Given this list of marker genes SERBP1 (SERPINE1 mRNA binding protein 1), STARD4, RBM20, ABHD13, ZBTB8A, MOSMO, KIAA0408, PM20D2, RORA, TTC28, DCBLD2, CLP1, NAMPT, UBE2D1, NEK1, UNC5D, PIK3R1, RASD1, FMNL2, PANK1, ERBIN, KRTAP2-4, RSBN1, ABCC2, DMD, PAPOLG, FBXW2, SKIL, SMC1B, FOXN2, INO80D, LEPROTL1, MXD1, RPS6KA6, TMEM131, GPC6, FAT1, DNAJB1, FZD6, PLAGL2, HDX, CDK14, SORCS1, ERGIC2, CREBRF, NOTCH2, GOLM2, TRMT9B, TANK, ZNF830, SPATA31A1, MTRF1L, ADISSP, SASH1, GRIA2, GSE1, SCG2, ANKRA2, SPRED1, POU3F1, SPTSSA, EGLN1, HIPK2, ZFP30, TDRP, CCDC71L, PDCL3, TNRC6B, SUZ12 (NCBI Gene Id 23512), FKBP5, TBL1XR1, COPS2, IQGAP2, UHRF1, CDS2, GRIN3A, CTXN2, PRR14L, SLC2A13, TMEM64, B4GALT4, ZBTB22, TMEM170B, IGF2BP2, TAF9, DYRK2, ANO3, DAG1, COLGALT2, GIGYF1, MCU, CDK17, PDE1C, HDAC8, ZBTB34, RP2, SOHLH2, ATL3, HSPH1, MARK1, CIPC, HOXD13, ING3, WNT5A, KPNA4, PIK3CA, PAN3, DND1 (NCBI Gene Id 373863), TBCA, NOL7, CREBBP (CREB binding protein), SNX12, SETD7, RC3H1, OTUD7B, PDS5A, AZIN1, TSEN15, TAOK1, KIN, CABLES2, RBM46, EMP2, SETD3, LARP4, HNRNPC, LIN7C, TNFSF11, INPP4A, AKAP10, STAC, RUNDC3B, ICAM5, ZNF468, LRRC37B, NTF3, HDGFL2 (NCBI Gene Id 84717), WNK3, DCLK1, MCM9, POLD3, USP38, TLL1, SON, AKT1, RETSAT, ZC3H12C (zinc finger CCCH-type containing 12C), MARCKSL1, TMPO, KMT2C, HUWE1, USP49, CASC3, SPATA31A7, HOXD8, LOXL2, ZNF566, DOCK10, ADARB2, SPIN1, XPR1, SIDT2, TRHDE, RSPRY1, EREG (epiregulin), MITF, FHIP1A, PCDH20, MYBL1, MAML3, TTC14, ERO1B, ANKRD28, RSRC1, MAFB, DNAJA2, VAV2, MATR3, MID1, VSTM2A, SMIM10L1 (small integral membrane protein 10 like 1), DDX5, CA13, SMIM7, SLC10A4, MED1, TMPRSS15, STIM2, EIF4G2, NDUFA4, ZFAND5, SCAI, HELZ, YPEL5, TRIM28, IRX2, RASA2, PSD3, SOS2, KIRREL1, LLGL2, CACNA2D1, CCZ1B, DIS3L2, TAF7L, CPNE8, SOCS5, IL6, SEPTIN2, ATP6V0A2, MARCHF5, MAGOHB, PPM1B, BCL2L11, SYNCRIP, ZCCHC14, KIAA0232, PITPNB, LSM14A, ZBTB43, PELI1 (pellino E3 ubiquitin protein ligase 1), PRKAR2B, ERP44, CRLS1, ABI2, HMGCS1, DNAJB12, B3GALT2, AHSA2P, NUFIP2, ITPA, NAV2, ARL6IP6, PDE7A, QTRT2, VKORC1L1, BCOR, PPP1R2, NPAS3, VEZF1, EPC1, POLR1A, HIF3A, ERI1, ELOC, ZNF148, NCL, RGPD1, LOXL1, B3GNT5, PDCD7, ARAP2, FIGNL1, ZNF614 (zinc finger protein 614), PLGRKT, WWP1, G2E3, SBK1, MAPK6, KDM7A, TMEM128, RB1CC1 (RB1 inducible coiled-coil 1), YTHDF3, GPD2, DCUN1D4, SEMA6D, MOB1B, MYLK, AMFR, UHMK1, ACBD5, CCNYL1, APH1A, TFPI2, TUT7, RPS6KA3, DNMT1, VCPIP1, CCDC34, SLC30A7, ONECUT2, ZMIZ1, PRMT1, SFPQ, C18orf54, LIN28B, FANCC, HSPE1-MOB4, ZNF704 (NCBI Gene Id 84737), DPY30, CNOT6L, SPATA31A6, BROX (BRO1 domain and CAAX motif containing), ATP2B4, SYT4, MED13, ARID1A, SDK1, LRRC58, PIM1, PHC3, RIF1, ANO5, DOCK6, LRFN3, MFAP3L, CCZ1, RCAN2, PRKCI, ELMOD2, MEX3C, PXDN, PDSS2, CNTLN, ZBTB41, RBL2, MAP2K4, CSNK1A1, DNAJB4, PPP1R14B, HOOK3, SEMA4B (NCBI Gene Id 56962), AEBP2, TOX, NRIP1, MBNL3, SMG7, EGR3, KCTD12, RB1, GCFC2, CSNK2B, DLG1, AGL, CPEB1, TMCC1, LANCL3, CNOT9, USP24, C2CD2, CXCL12, ATP2B2, ALK, HDAC4, ANKRD13C, ARFGEF3, TM2D3, YTHDF1, SAP130, KRAS, PITPNM3, COL4A1, RASEF, PTPRK, KLHL15, ZMPSTE24, ZBTB21, GNAI3, HYCC2, TMC7, MBTD1, SLC18B1, ZNF529, TOX3, STRN3, SKI, RNF38, STXBP4, CMTM6, CADM2, SAR1B, PRMT3, SYT16, MAPK8, UBN2, GABBR2, MFSD14B, GNA11, DDX6, SAMD8, RNPC3, SLC44A1, RMI1, ZDHHC21, MLLT3, BPTF, CCDC68, HUS1, OTX2, NAALADL2, RAPH1, PMS1, MBOAT2, SSR1, MFSD13A, VGLL3, ZBBX, MAP3K3, DYRK1A (NCBI Gene Id 1859), HNRNPR, SETBP1, MYEF2, WWC3, ARHGAP29, AFF2, TLNRD1 (talin rod domain containing 1), NUP98, SOAT1, CCND2, TUT4, FZD3, TMEM63B, TBX3 (T-box transcription factor 3), DNAL4, CHUK, RBM27, TCP11L2, PLPP2, ROR1, DUS4L, TMEM59 (transmembrane protein 59), SRP54, API5, RCC1L, USP42, CSNK1G3, SELENOI, MAP3K5, UGCG, USP16, UBR5, PRDM4, STX16, STOML2, FLI1, BRD3, BAG5 (NCBI Gene Id 9529), ZNF207, PPP2R1A, TET3, IER3IP1, MGARP, ATP2A2, ARL6IP5, TSC22D2, PID1, MMGT1, ZNF547, SUPT3H, MTMR4, ATXN7L3, CCNC, RAF1, ETF1, INVS, SOCS6, AGPAT1, ZNF248, SGO2, BARD1, SCYL2 (NCBI Gene Id 55681), IKZF2, SNRK, RABEP1, COX15, CARF (NCBI Gene Id 95855), STK24, WDR44, EFEMP1 (EGF containing fibulin extracellular matrix protein 1), CYRIB, TP53INP1, GMCL1, PSIP1, HECTD2, LRRTM4, TSPAN3, BPNT2, GABPA, CRY1, SLC25A16, MPZ, CD96, MSI2, TGFBR1, SMC1A, ATP13A3, ARX, BOLL, SMURF2, MCL1, COL1A1, MOB4, MDM4, SNX18, RBMS3, GRPEL2, RBBP4, ALKBH1, RETREG1, FAM169A, SH3RF1, PTPRZ1, LETM2, GPR63, FOSL2, SPATA31A5, XIAP, FKBP1A, GORAB, IDS, GABRG1, ZNF28, OSGEP, FAM76B, KDM2A, SPATA31A3, ZFAND4, UTRN, MAPK1, ZMYM3, SCN9A, PELI2, SLC35A3 (solute carrier family 35 member A3), GABRA4, BBS9, RICTOR, DOCK9, L2HGDH, ETNK1, FSD1L, PA2G4, SHISAL1, MLLT1 (MLLT1 super elongation complex subunit), BCL2L10, C5orf24, SOX6, SIAH2, CCDC14, ENTPD7, ARGLU1 (NCBI Gene Id 55082), AZIN2, RBPJ, PIK3R3, DNAJB11, TSPAN9, LPGAT1, TCF7L2, HOXA5, PUM2, GFPT1, ATF7IP (activating transcription factor 7 interacting protein), FYTTD1, KLF11, PTBP2, YBX3, BTBD10, SPATA6, ICE2, CAMTA1, ZNF800, ANKS1A, CNOT7, SLC25A44, MYC, TSLP, BMPR1A, ZNF583, PRKAA2, IL6R, GPATCH2, CPSF6, ADGRG2, UBE2H, CAMSAP2, IPO8, CPEB2, CD47, HOXB7, CPEB4, DNMT3B, DTNA, ITPRIPL2, NAA50, STOX2, PITPNM2, PARP11, PTBP3 (NCBI Gene Id 9991), ZNF875, MEF2C, ZNF648, MAP3K7, ROBO1, YBX1, ELAVL1, EIF1AX, LAMTOR1, PI4K2B, BACH2, ACVR1C, YWHAZ, LRRC8C, RNFT2, SLF2, KCNJ2, SGCZ, here is a description of the gene set: studied in species Homo sapiens Genes predicted to be targets of miRBase v22 microRNA hsa-miR-548bb-3p in miRDB v6.0 with MirTarget v4 prediction scores > 80 (high confidence targets). from publication Chen Y, Wang X (PMID 31504780) Human Gene Set: MIR548BB_3P